The following is a description of a gene set: Bicarbonate-wasting renal tubular acidosis studied in species Homo sapiens Human Gene Set: HP_BICARBONATE_WASTING_RENAL_TUBULAR_ACIDOSIS, and this is the list of marker genes: GATM, EHHADH, SLC34A1, NDUFAF6, SLC4A4